The following is a description of a gene set: Resting chondrocyte Human Gene Set: HE_LIM_SUN_FETAL_LUNG_C0_RESTING_CHONDROCYTE studied in species Homo sapiens from publication He P, Lim K, Sun D, Pett JP, Jeng Q, Polanski K, Dong Z, Bolt L, Richardson L, Mamanova L, Dabrowska M, Wilbrey-Clark A, Madissoon E, Tuong ZK, Dann E, Suo C, Goh I, Yoshida M, Nikolić MZ, Janes SM, He X, Barker RA, Teichmann SA, Marioni JC, Meyer KB, Rawlins EL (PMID 36493756), and this is the list of marker genes: SNORC, MMP16, TENM3, YPEL2, COL11A2, SCARB1, FLNB, CSPG4, SOX5, SCUBE3, MIOS, MATN1, BMPR1B, FGFR2, PDE4DIP, TRPV4, PCOLCE2, SOX6, THSD4, SOX8, MATN3, SDK2, PRELP, CSGALNACT1, SUSD5 (NCBI Gene Id 26032), MIA, WWP2, HSPA6, CNMD, RFLNA, S100A1, PEG3, FGFRL1, FRZB, DAAM2, SLC2A1, STK26, COL2A1, HAPLN1, PDPN, ART3, MPZL2, CYP26B1, ACAN, NOG, ITM2A, COL11A1, ITGA10, FIBIN, COL8A2, TRIM9 (tripartite motif containing 9), COL9A1, SNAI1, FGFR3, PYGL, IL16, KLF5, COL9A2, TRAPPC8 (trafficking protein particle complex subunit 8), TTYH1, RARG, SLC29A1, CDH7, RNF144B, DHRS3, GDF5, CHADL, COL24A1, EPYC, ENPP1, CHST11 (carbohydrate sulfotransferase 11), STEAP1, CFH, SORBS2, NEDD4, SOX9, KLHL13, CAPN6, CXXC5, PRRX1, CRISPLD1, IGF2-AS, S100B, DOCK8, MATN4, SYT8, UCMA, COL27A1, DLK1, HMGCLL1, CHAD, TNFRSF11B, CDC42EP3, FGFBP2, ITGB5, COL12A1, PRKCD, LINC00511, C1GALT1, PENK, NEDD9, CPM, WFDC2, PRDM16, FRY, COL9A3, WIF1, NRK, C1QTNF3, CTHRC1 (NCBI Gene Id 115908), COL15A1